Given this list of marker genes H2BC13, H1-2, RBMXL2, CENPA, H2BC21, H2BC12, H2AX, H2AZ1, H2BC11, H1-6, H2AC18, H1-0, H2AC8, H2AC6, here is a description of the gene set: Genes in the cancer module 89. Human Gene Set: MODULE_89 studied in species Homo sapiens